Given this list of marker genes PEX2, GLRX5, IFT74, SLC30A10, LARS1, FTH1, MKS1, NPHP1, ABCG8, MPV17, ADK, EARS2, TRIM32, ACADS, MTX2, VCP, GABRD, APOE, RINT1, TARS2, PDPN, PHKG2, ACOX1, ENO3, ZPR1, YARS1 (tyrosyl-tRNA synthetase 1), PEX1, HNF4A, COL6A3, VPS4A, IFIH1, HMGCL, OBSCN, CIDEC, MRPS7, TBX1, PEX6, PHKG1, SCAPER, NDUFA4, LIG3, MT-CO3, CYP7A1, FBP1, PFKM, LDLR, TRMU, HMGCR, NDUFAF1, APOB, TPM3, BBS4, LDLRAP1, LMNA, ACTA1, IFT27, RRM2B, PPARG, DEF6, SLC25A20, HADHA, COQ9, ALMS1, LPIN1, ABCG5, PCSK9, PHKB, SPTBN1, AGPAT2 (1-acylglycerol-3-phosphate O-acyltransferase 2), SLCO1B3, SAR1B, TTN, PEX16, POLG, LIPE, PEX5, DHCR7, ETFA, DOCK2, PLIN1 (perilipin 1), COA8, CAVIN1, DNAJC19, FTL, HEPACAM (hepatic and glial cell adhesion molecule), DDOST, ATP7B, IARS1, SLC25A13, LUZP1, KBTBD13, NDUFS4, PTEN, SPEN, PDSS2, HNF1B, DGUOK, ARSA, ACBD5, LRPPRC, ETFDH, MYPN, NAA10, NSMCE2, KCNJ18, HMGCS2, KMT2B, GNB2, STAC3, RMND1, POLG2 (DNA polymerase gamma 2, accessory subunit), PEX14, TOMM7, PYGL, BSCL2, TPM2, MT-CO1, SCO1, BBS7, PEX12, BBS5, MRPL3, PEX3, PEX10, UNC45A, BBS9, HSPG2, PIGA, MYH7, HBB, COL6A2, SDCCAG8, DPM1, NHLRC2, ALDOB, SLC22A5, GABRA3, HEXB, PRDM16, ACADM, ACAD9, PYGM, RERE, CPT1A, HADHB, ATP6AP2, GAA, BBS10, CYP19A1, PCK1, FOS, KLHL41, PEX19, COQ4, BBIP1, HSD17B4, SLC40A1, IFT172, MSTO1, CCDC115, SUCLG1, CP, PHKA1, BCS1L, COL12A1, SCN4A, ARL6, SCLT1, AFG3L2, COQ2, UBE4B, ISCU, MRPL44, MCCC1, GYG1, HNRNPA2B1, PSAP, SLC37A4, CAV1, MT-TN, MIPEP, TRAPPC11, GM2A, SLCO1B1, TYMP, NGLY1, ABCD1, AKR1D1, COX6A2, KHK, ETFB, PRKCZ, FARS2, MTTP, CLPB, PNPLA2, PGM1, PLAAT3, SLC11A2, MCOLN1, XRCC4, TMEM199, KCNAB2, ATP6AP1, NFS1, HADH, PCK2, CPT2, SLC2A2, BLM, FOCAD, KDM1A, SKI, PEX13, CFAP418, SDHA, POLD1, COL6A1, PCYT1A, ARMC5, PMM2, LMNB2, SHARPIN, KCNE3, LYRM4, BBS1, LIPA, COQ8A, RNU7-1, CEP290, TFAM, POLR3A, TTC8, WDPCP, PTRH2, GYS1, SELENON, MARS1, SURF1, BBS2, CASZ1, FARSA, ABHD5, PEX26, BMP6, MT-TE, ACADVL, PHKA2, AKT2, SLC51B, ACSL5, GPD1, MKKS, HNRNPA1, MMP23B, BBS12, TKFC (triokinase and FMN cyclase), CACNA1S, NEB, CBS, STEAP3, VPS33A, GNAS, COX15, CARS2, GLA, CHCHD10, LZTFL1, MICOS13, PEX11B, FARSB, HEXA, CEP19, here is a description of the gene set: Human Gene Set: HP_ABNORMAL_TISSUE_METABOLITE_CONCENTRATION studied in species Homo sapiens Any deviation from the normal concentration of a metabolite in a tissue. Abnormal tissue metabolite concentration